The following is a description of a gene set: species: Homo sapiens Human Gene Set: GOBP_PROTEIN_DESTABILIZATION Any process that decreases the stability of a protein, making it more vulnerable to degradative processes or aggregation., and this is the list of marker genes: SERF1B, CDKN2A, HTT, XBP1, BTRC, RAD23A, CAPN3, TRIM21, SIAH1, SRC, GSN, ISOC2, SENP2, MYLIP, CHFR, KDM8, BMP2, SERF2, GGA3, SNCA, FBXL3, CCDC88C, CDC73, IRGM, PLK1, MDM2, SIRT1, DERL1, UTP25, FBXO4, FBXW11, HDAC6, MTMR1, PEX2, SIRT6 (NCBI Gene Id 51548), VPS35, NR1D1, COMMD1, IAPP, PYHIN1, EP300 (E1A binding protein p300), PRNP, RNF139, SOX17, MUL1, ID1, PRKN, DAZAP2, RNF5, KLF1, MTOR, CUL3, CTSH, SERF1A, CREBBP, PRKDC